The following is a description of a gene set: Human Gene Set: REACTOME_TRIGLYCERIDE_CATABOLISM Triglyceride catabolism studied in species Homo sapiens, and this is the list of marker genes: PRKACB, PNPLA4, GPD2, FABP6, FABP9, PRKACA, PPP1CC, FABP4, PPP1CA, CAV1, FABP3, PLIN1, LIPE, ABHD5, FABP7, PNPLA5, PRKACG, PLIN3, PPP1CB, FABP5 (NCBI Gene Id 92424), FABP12, FABP2, MGLL, FABP1